The following is a description of a gene set: Genes co-regulated in uterus during a time course response to progesterone: SOM cluster 2. Human Gene Set: YAO_TEMPORAL_RESPONSE_TO_PROGESTERONE_CLUSTER_2 from publication Yao MW, Lim H, Schust DJ, Choe SE, Farago A, Ding Y, Michaud S, Church GM, Maas RL (PMID 12554760) Human infertility and recurrent pregnancy loss caused by implantation defects are poorly understood. Hoxa-10-deficient female mice have severe infertility and recurrent pregnancy loss due to defective uterine implantation. Gene expression profiling experiments reveal that Hoxa-10 is an important regulator of two critical events in implantation: stromal cell proliferation and local immunosuppression. At the time of implantation, Hoxa-10 mediates the progesterone-stimulated proliferation of uterine stromal cells. Hoxa-10 mutants express a stromal cell proliferation defect that is accompanied by quantitative or spatial alterations in the expression of two cyclin-dependent kinase inhibitor genes, p57 and p15. Hoxa-10 deficiency also leads to a severe local immunological disturbance, characterized by a polyclonal proliferation of T cells, that occurs in place of the normal progesterone-mediated immunosuppression in the periimplantation uterus. species: Mus musculus, and this is the list of marker genes: GCNT2, NAT8, ERRFI1, BCL2, KIAA1217, SOX3, TTC14, CCNL2, DTD2, ELN, OGT, MMP12, GNAO1, CLK4, RBM39, CDON, KLRG1, NAPB, ZMYM6, FOS, TIPARP, SOX5, SH3RF1, NMU, PLA2R1, CLK1, PAXBP1, HNRNPU, PRSS58, AASS, THBS2, PKLR, KRTDAP, CYP1A2, MEG3, ESR1, UBAP2L, RAB14, EPB41L4B (erythrocyte membrane protein band 4.1 like 4B), NR0B1, AKAP9, SRSF7, FUBP1, SLC4A1, RPP30, TACR2, MYL11, TARDBP, CAPN3, CCL27, HGD, APOA5, PIK3CD (phosphatidylinositol-4,5-bisphosphate 3-kinase catalytic subunit delta), SMYD1, NPTX1, TNXB